The following is a description of a gene set: A form of torticollis in which the head is drawn back, either due to a permanent contractures of neck extensor muscles, or to a spasmodic contracture. Human Gene Set: HP_RETROCOLLIS Retrocollis species: Homo sapiens, and this is the list of marker genes: FUS, PRKRA, SPTLC1, MAPT, KMT2B, TSPOAP1, SIGMAR1, SPG11, ALS2